The following is a description of a gene set: studied in species Mus musculus Mouse Gene Set: GOMF_LARGE_RIBOSOMAL_SUBUNIT_RRNA_BINDING Binding to large ribosomal subunit RNA (LSU rRNA), a constituent of the large ribosomal subunit. In S. cerevisiae, this is the 25S rRNA., and this is the list of marker genes: Rpl19, Rpl17, Rpusd4, Rpl23a, Rpl23, Rplp0, Mrpl11, Rpl12